The following is a description of a gene set: Human Gene Set: GOBP_DICHOTOMOUS_SUBDIVISION_OF_AN_EPITHELIAL_TERMINAL_UNIT studied in species Homo sapiens The process in which an epithelial cord, rod or tube bifurcates at its end., and this is the list of marker genes: PLXNA1, AREG, VANGL2, CELSR1, SEMA3C, PLXND1, NRP1, FOXD1, CTSH, TFAP2C